The following is a description of a gene set: Human Gene Set: MILICIC_FAMILIAL_ADENOMATOUS_POLYPOSIS_UP species: Homo sapiens Top genes up-regulated in colon epithelium biopsies from FAP (familial adenomatous polyposis) patients with mutated APC. P-cadherin is normally expressed in the basal layer of squamous epithelia and absent from the healthy intestine and colon. We have previously shown it to be expressed in all inflamed, hyperplastic, and dysplastic intestinal and colonic mucosa. This study aimed to better understand the mechanisms controlling the expression of P-cadherin and the biological effects of its ectopic presence in the intestine and colon. We investigated the CpG methylation status of the P-cadherin (CDH3) promoter and P-cadherin mRNA and protein expression in cases of familial and sporadic colorectal cancer (CRC). The CDH3 promoter was hypomethylated in colonic aberrant crypt foci, in CRC, and, occasionally, in the normal epithelium adjacent to cancer, demonstrating a potential field effect of cancerization. The hypomethylation was also associated with induction of P-cadherin expression in the neoplastic colon (P < 0.0001). We then created transgenic mice that overexpressed P-cadherin specifically in the intestinal and colonic epithelium under the liver fatty acid binding protein promoter. Forced ectopic expression of P-cadherin accompanied by indomethacin-induced inflammation resulted in a 3-fold higher crypt fission rate within the small and large intestines in the homozygous mice compared with the wild-type animals (P < 0.02). We conclude that epigenetic demethylation of the P-cadherin promoter in the human intestine permits its ectopic expression very early in the colorectal adenoma-carcinoma sequence and persists during invasive cancer. Induced P-cadherin expression, especially in mucosal damage, leads to an increased rate of crypt fission, a common feature of clonal expansion in gastrointestinal dysplasia. from publication Milicic A, Harrison LA, Goodlad RA, Hardy RG, Nicholson AM, Presz M, Sieber O, Santander S, Pringle JH, Mandir N, East P, Obszynska J, Sanders S, Piazuelo E, Shaw J, Harrison R, Tomlinson IP, McDonald SA, Wright NA, Jankowski JA (PMID 18829530), and this is the list of marker genes: LCN2, FZD3, TACSTD2, PCSK1, SLCO1B3, XIST, DEFA6, MSX2, CEMIP, CDH3